The following is a description of a gene set: species: Mus musculus Mouse Gene Set: CUI_TREG_LTA2_B1_RESPONSE_UP Cytokines mediate cell-cell communication in the immune system and represent important therapeutic targets. A myriad of studies have highlighted their central role in immune function, yet we lack a global view of the cellular responses of each immune cell type to each cytokine. To address this gap, the authors created the Immune Dictionary, a compendium of single-cell transcriptomic profiles of more than 17 immune cell types in response to each of 86 cytokines (>1,400 cytokine-cell type combinations) in mouse lymph nodes in vivo. A cytokine-centric view of the dictionary revealed that most cytokines induce highly cell-type-specific responses. For example, the inflammatory cytokine interleukin-1β induces distinct gene programmes in almost every cell type. A cell-type-centric view of the dictionary identified more than 66 cytokine-driven cellular polarization states across immune cell types, including previously uncharacterized states such as an interleukin-18-induced polyfunctional natural killer cell state. from publication Cui A, Huang T, Li S, Ma A, Pérez JL, Sander C, Keskin DB, Wu CJ, Fraenkel E, Hacohen N (PMID 38057668) Genes positively differentially expressed in cell type: Treg upon treatment with cytokine: LT-α2/β1 in mouse lymph nodes in vivo., and this is the list of marker genes: Hdac7, Mknk2, Irf2bpl, Tcf7, Fkbp4, Erh